The following is a description of a gene set: studied in species Homo sapiens The secretory membrane system allows a cell to regulate delivery of newly synthesized proteins, carbohydrates, and lipids to the cell surface, a necessity for growth and homeostasis. The system is made up of distinct organelles, including the endoplasmic reticulum (ER), Golgi complex, plasma membrane, and tubulovesicular transport intermediates. These organelles mediate intracellular membrane transport between themselves and the cell surface. Membrane traffic within this system flows along highly organized directional routes. Secretory cargo is synthesized and assembled in the ER and then transported to the Golgi complex for further processing and maturation. Upon arrival at the trans Golgi network (TGN), the cargo is sorted and packaged into post-Golgi carriers that move through the cytoplasm to fuse with the cell surface. This directional membrane flow is balanced by retrieval pathways that bring membrane and selected proteins back to the compartment of origin. part of: Vesicle-mediated transport Reactome Pathway: Membrane Trafficking, and this is the list of marker genes: CHMP6, GJC1, ALPP, ACTR3, GOSR1, SEC24B, MAP1LC3B, TBC1D25, UBB, DENND5B, RAB11A, PAFAH1B2, SNF8, TBC1D13, CSNK1D, VTA1, ARPC3, PIP5K1C, TMED9, RAB38, RAB27B, KIF18A, CHML, DENND1B, STAM2, TUBA1A, USO1, OPTN, KIF5B (kinesin family member 5B), AGFG1, KIF6, RIN1, COPS7B, INS, RINL, TBC1D2, RAB35, GBF1, DENND6B, TMF1, HIP1R (huntingtin interacting protein 1 related), DENND5A, GJD4, STON2, GOLIM4, CD3D, TGOLN2 (NCBI Gene Id 10618), PRKAB2, SH3D19, GORASP1, COL7A1, SEC24D, GJD2, KIF5C, EPGN, AAK1, LNPEP, CHMP4B (charged multivesicular body protein 4B), GALNT2, MON1B, SYNJ1, EXOC1, F8, USP6NL, VPS4B, ANKRD27, AP1G1, TUBB2A, KIF5A, SEC31A, AP4E1, UBQLN1, UBA52, VPS37B, PACSIN2, PACSIN3, STX5, AREG, GJA8, KIF19, TBC1D1, AP2A1, VPS37A, AP3S1, VPS28, ARF4, COG4, TUBB4A, GJB4, COPB2 (COPI coat complex subunit beta 2), WNT5A, PUM1, FOLR1, RACGAP1, KLC2, RAB39A (RAB39A, member RAS oncogene family), TRAPPC6B, TUBA3E, GRIA1, GJD3, CAPZB, SEC22C, BIN1, CD55, KIF15, RABGEF1, IL7R, RINT1, BLOC1S1, OCRL, KIF9, REPS1, ARFGAP2, CAPZA2 (NCBI Gene Id 830), LMAN1, PRKAG1, CLTB, KIF1C, STX16, KDELR1, TUBAL3, PPP6R1, RAB21, BLOC1S6, EPS15L1, DCTN3, ACTR2, STAM, HPS4, DTNBP1, DNM3, RAB3GAP2, TBC1D10C, ZW10, NAA38, ARF1, MAN2A2, TUBB8, CHMP2B, SEC23A, COPS3, GNS, ACTG1, DYNC1I1, VPS36, AVPR2, GGA1, EXOC3, GJA9, TRAPPC4, KIF25, EPS15, KIF13B, BICD2, SEC23IP, COPE, REPS2, SAR1B, DVL2, KIFC1, KIF3B, VPS37C, COG8, TRIP10, GJB1, GJA4, AP1S2, ACBD3, KIF12, KIF16B, E, KIF3A, FTH1, FZD4, TBC1D4, SYT9, CLVS2, ARFGAP3, PICALM, GJA10, TRAPPC1, RALGAPB, RIN2, VAMP3, RAB1A, MYO6, KIF1B, COPA, PRKAB1, GJB2, YWHAE, TUBA4A, COPG2, EGF, SNX2, DENND1C, DNASE2, AKT2, APOB, ARPC1A, NSF, AP2M1, VAMP8, CLVS1, DCTN5, SNX9, SEC16A, VPS53, RIN3, EGFR, NAPA, DENND4C, GOLGA5, CFTR, GOLGB1, AP3B1, TBC1D17, SH3KBP1 (NCBI Gene Id 94010), F5, AP1S1, TOR1A, SNX5, KIF18B, RABEP1, TF, TUBB4B, SYS1, FNBP1, KIF2B, LMAN2L, COPS4, PPP6C, GJC2, GJB6, KIF23, SEC24A, RAB31, MVB12B, USE1, LMAN1L, TRAPPC2, RAB30, ULK1, ADRB2, RAB33A, TRAPPC2L, BET1L, RAB5A, DNM2, SNAP23, GGA2, GDI2, GOSR2, SLC18A3, VPS51, LDLR, KLC3, ARRB2, TRIP11, GRB2, STX6, COPS2, MYO1C, AGTR1, BICD1, ACTB, KIF22, SEC13, SPTA1, CYTH3, TFRC, COPS6, SH3GL3, TUBB3, RAB32, SORT1, ARPC5, RAB5C, RALGAPA2, VPS52, TRAPPC6A, KIF26B, CHM, FTL, TOR1B, SCOC, WASL, MYO5A, KDELR3, ACTR1A (NCBI Gene Id 10121), GGA3, TUBA4B, GJB3, SERPINA1, KIF11, ASPSCR1, ANK1 (NCBI Gene Id 286), AP2S1, CHMP7, CHMP2A, TMEM115, BNIP1, AKT1, RAB3GAP1 (NCBI Gene Id 338380), TRAPPC8, RAB13, CPD, COG7, GPS1, RAB1B, COPS7A, CLTC, SBF1, GAPVD1, TMED3, SEC24C, HBEGF, KIF28P, TUBA1C, GOLGA2, RAB36, RAB4A, SPTB, SPTAN1, ARFRP1, GRK2, CAPZA3, RAB3IL1, DYNC1H1 (dynein cytoplasmic 1 heavy chain 1), ARF5, LMAN2, DENND2D (DENN domain containing 2D), STX10 (NCBI Gene Id 8677), EPN1, EXOC5, BLOC1S3, PRKAA2, PLA2G4A, MYH9, TBC1D10B, ARFGAP1, DENND1A, NAPG, HSPA8, NAPB, GALNT1, KIF4A, TRAPPC12, TRAPPC13, SRC, SPTBN1, COPG1, AVP, SYT2, CCZ1, DYNC1I2, PLA2G6, DYNC1LI1, TRAPPC10, NECAP2, AP1B1, ANKRD28, YWHAZ, ARPC2, KLC1, CLINT1, HGS, TUBA3C, TJP1, GAK, TMED7, TBC1D14, TRAPPC11, SEC22B, RAB39B, SH3GL2, MAN2A1, COPB1, GABARAPL2, FNBP1L, UBQLN2, DCTN1, KLC4, STXBP3, CHMP3, EXOC4, TBC1D20, AP2B1, YWHAQ, PIK3C2A, CTSC, PLIN3, SNX18, GABARAP, KIF2A, RHOQ, RABEPK, TMED10, SCARB2, VPS37D, COG1, BLOC1S4, COG6, VPS25, MADD, SNAP91, AP4M1, PAFAH1B1, VPS54, RAB27A, SH3GL1, AP1M1, CD3G, YWHAB, TGFA, TBC1D24, PREB, TSC1, PAFAH1B3, RAB43, BTC, EREG, SNAP29, YWHAH, PPP6R3, RABGAP1, ARL1 (NCBI Gene Id 400), RAB12, CD59, DNM1, RAB6A, GJB7, DCTN2, TUBB2B, GCC2, SYTL1, GRK3, KIF21A, KIF3C, RAB5B, DENND6A, KIF20A, MIA3, DENND4B, NECAP1, MAN1A2, VAMP4, ARF3, SURF4, FCHO2, CTTN, DENND2A, HIP1, CNIH1, GCC1, DENND3, MIA2, COG3, GJA3, TUBB8B, KIFC2, LDLRAP1 (NCBI Gene Id 81862), SPTBN5, TRAPPC3, VTI1A, CYTH1, CD4, TUBA8, CYTH4, TXNDC5, TBC1D16, SEC16B, COPS5, GJB5, APP (NCBI Gene Id 351), GJA5, MVB12A, HPS1, VAMP7, TBC1D8B, AP4B1, SYT1, ANK2, PRKAG2, SEC22A (NCBI Gene Id 26984), AMPH, YWHAG, ANK3, KIF1A, ALS2, TBC1D3, TBC1D15, NBAS, CENPE, AKT3, ARPC4, CUX1, CCZ1B, PRKAG3, RAB3IP, TFG, VPS45, UBC, CBL, SEC31B, C2CD5, RAC1, FCHO1, LRP2, CALM1, TPD52L1, CLTA, SGIP1, SBF2, SLC2A4, AGPAT3, GOLGA4 (NCBI Gene Id 2803), STX17, SLC2A8, CNIH2, VPS4A (NCBI Gene Id 27183), STX18, STON1, POLG, KIF2C, CHMP5, TUBB1, CHMP4A, NAA30, KIF4B, RGP1, DYNLL2, KIF27, YIPF6, MAN1C1, SNAPIN, ARCN1, KIF20B, EXOC6, ACTR10, DYNC1LI2, TUBA3D, RAB7A, GOLGA1, MAN1A1, RAB7B, SYNJ2, TSG101, VAMP2 (vesicle associated membrane protein 2), AP1G2, IGF2R, GDI1, AP4S1, KIAA0319, EXOC7, M6PR, ALS2CL, AP1S3, RIC1, DYNLL1, DCTN6, COPZ2, ARF6, COG2, TACR1, TRAPPC5, TPD52, TBC1D7, UBAP1, SFN (stratifin), GJA1, RAB11B, EXOC2, KIF26A, CLTCL1, MON1A, CNIH3, DENND2C, DAB2, YKT6, RAB9A, RAB14, CTSZ, KIFAP3, RAB6B, SPTBN4 (spectrin beta, non-erythrocytic 4), BET1, ITSN1, ITSN2, RAB3A, NAA35, DNAJC6, SYT11, COPZ1, EPN2, NEDD8, ARFIP2, TBC1D10A, STX4, RALA, AP1M2, RAB8A, RAB18, SYT8 (synaptotagmin 8), RAB33B, KIF21B, ARRB1 (NCBI Gene Id 408), EXOC8, CHRM2, CHMP4C, SPTBN2, TRAPPC9, RAB9B, PACSIN1 (protein kinase C and casein kinase substrate in neurons 1), AP2A2, RPS27A, TSC2 (TSC complex subunit 2), DENND2B (NCBI Gene Id 6764), KDELR2, DCTN4, COPS8, TUBA1B, COG5, CAPZA1, RAB10, RHOBTB3, MCFD2, TMED2, DENND4A, SCFD1, RAB8B, RAB41, CYTH2, TUBB6